The following is a description of a gene set: Mouse Gene Set: GOMF_PHOSPHOLIPASE_A2_ACTIVITY Catalysis of the reaction: a 1,2-diacyl-sn-glycero-3-phospholipid + H2O = 1-acyl-sn-glycero-3-phospholipid + a fatty acid. This reaction removes the fatty acid attached to the sn2-position. Substrates include phosphatidylcholine, phosphatidylethanolamine, choline plasmalogen and phosphatides. species: Mus musculus, and this is the list of marker genes: Lcat, Plb1, Pla2g15, Plaat1, Pla2g4a, Pla2g5, Abhd3 (NCBI Gene Id 106861), Proca1, Pla2g4f, Pla2g2f, Pla2g4d, Prdx6b, Pla2g4c, Pla2g1b (NCBI Gene Id 18778), Pgap6, Oc90, Pla2g3, Pla2g2d, Pla2g12b, Pla2g4b, Plaat3, Ppt1, Prdx6, Pla2g6, Pla2g7, Plaat5, Pla2g2e, Pnpla2, Anxa3, Pla2g2a, Scgb1a1, Pla2g12a, Casp3, Pla2g10, Pla2g2c, Pnpla8, Anxa1, Plaa, Pnpla3, Anxa2, Pla2g4e